Given this list of marker genes Enkur, Plscr2 (NCBI Gene Id 18828), Shank1 (NCBI Gene Id 545962), Mypn, Adam17, Syngap1, Rufy2, Evl, Fmn1, Cttnbp2, Acp1, Vasp (NCBI Gene Id 22323), Sh2d2a, Hip1r, Grik5 (glutamate receptor, ionotropic, kainate 5 (gamma 2)), Cd2ap, Afap1, Ilk, Noxa1, Wasf2, Qki, Cyba, Uvrag, Shank2, Drd4, Afap1l2, Gja1, Plscr1, Arhgap6, Zfp384, Sh3bgr, Lrp2, Adam9, Rufy1, Arhgap31, Zfp106, Adam15, Fut8, Cbl, Sos1, Prrt2, Pttg1, Ostf1, Grb2, Plscr3, Ptpn6, Dock1, Dab2ip, Abi1, Dennd1a, Adam10, Dpysl3, Rims1, Wipf3, Picalm, Sgip1, Mapt, Abl1, Sh3kbp1, Pak3, Gpx1, Elmo3, Akap5 (A kinase anchor protein 5), Map4k3, Prkce, Rad9a, Espn, Sh3bp2, Arhgap27, Sh3bp5, Sh3bgrl, Adam12, Mvb12a, Dock4, Crb3, Dtx1, Ptpn12, Sh3bgrl2, Errfi1 (NCBI Gene Id 74155), Tom1l1, Bcar1, Abi2, Inpp5d, Usp8, Arhgap1, Ncf1, Arhgap17, Hcls1, Adam19, Sirpa, Wipf1, Was, Inppl1 (inositol polyphosphate phosphatase-like 1), Cd3e, Elmo1, Lancl1, Cblc, Dnm2, Eps15, Trp53bp2, Ptpn22, Crk (NCBI Gene Id 12928), Khdrbs3, Efs, Khdrbs2, Casp9, Mical1, Nckipsd, Cntnap1, Dock3, Enah, Dnajc6, Shank3, Khdrbs1, Synj1, Dnm1, Pdcd6ip, Sh3gl1, Lyn, Reps1 (RalBP1 associated Eps domain containing protein), Itgb1bp2, Cit, Elmo2, Synj2, Inpp5j, Sh3bp1, Ccdc6, here is a description of the gene set: species: Mus musculus Binding to a SH3 domain (Src homology 3) of a protein, small protein modules containing approximately 50 amino acid residues found in a great variety of intracellular or membrane-associated proteins. Mouse Gene Set: GOMF_SH3_DOMAIN_BINDING